Given this list of marker genes HES1, MAG, SERPINE2, LIF, TTBK1, IL6ST (NCBI Gene Id 3572), MIR142, BMP2, NOTCH1, ID2, BIN1, SHH, CLCF1, here is a description of the gene set: Any process that activates or increases the frequency, rate or extent of astrocyte differentiation. Human Gene Set: GOBP_POSITIVE_REGULATION_OF_ASTROCYTE_DIFFERENTIATION studied in species Homo sapiens